Given this list of marker genes SLC25A23, XRCC6, FXYD2, TRPV4, ZFP36L1, AQP1, EFHD1, CAPN3, MICU1, ABCB1, LETM1, AKR1B1, SLC12A6, FBP1, here is a description of the gene set: Human Gene Set: GOBP_CELLULAR_RESPONSE_TO_SALT_STRESS Any process that results in a change in state or activity of a cell (in terms of movement, secretion, enzyme production, gene expression, etc.) as a result of a stimulus indicating an increase or decrease in the concentration of salt (particularly but not exclusively sodium and chloride ions) in the environment. studied in species Homo sapiens